Given this list of marker genes ZNF793, VCAN, MAP3K20, GATA4, LRR1, FAM86B1, EEF2KMT, EPB41L4B, PRR15, CAMK4 (NCBI Gene Id 814), ZIC1, BCAM, FAM86C1P, IGDCC3, BHMT2, PFKP, EFNA5, AKIRIN1, DENND4A, TFG, TNFRSF11B (NCBI Gene Id 4982), KLHL9, ADAR, DYRK2, TMEM245, FAM86B2, GCC1, ADAM10, HMG20A, TCIM, INO80D, C15orf40, HTR3C, ZNRF3, KDM5B, PATE1, KDM5C, SLC6A4, EMC8, SMAP1, ORC3, TUBB4A, ONECUT2, KAZALD1, MED7, SERPINB13, LRPAP1, ATP1B4, MEPCE, KCNE5, HOXA5, here is a description of the gene set: studied in species Homo sapiens Genes predicted to be targets of miRBase v22 microRNA hsa-miR-3198 in miRDB v6.0 with MirTarget v4 prediction scores > 80 (high confidence targets). Human Gene Set: MIR3198 from publication Chen Y, Wang X (PMID 31504780)